Given this list of marker genes Tbc1d24, Adcyap1r1, Rbx1-ps, Tsc1, Rbx1, Tldc2, Ggt7, Rnf146, Oxr1, Ncoa7 (NCBI Gene Id 211329), Usp25, Scly, Keap1, Macroh2a1, Meak7, Hspb1, Mctp1, Reg3b, here is a description of the gene set: Any process that stops, prevents or reduces the frequency, rate or extent of response to oxidative stress. species: Mus musculus Mouse Gene Set: GOBP_NEGATIVE_REGULATION_OF_RESPONSE_TO_OXIDATIVE_STRESS